The following is a description of a gene set: The replication of a centrosome, a structure comprised of a pair of centrioles and peri-centriolar material from which a microtubule spindle apparatus is organized. Mouse Gene Set: GOBP_CENTROSOME_DUPLICATION species: Mus musculus, and this is the list of marker genes: Ccdc57 (coiled-coil domain containing 57), Plk2, Chmp4c (NCBI Gene Id 74324), Cep152, Nat10, Vps4b, Brsk1, D7Ertd443e, Chmp3, Rock2, Cenpj, Pdcd6ip, Stil, Cdk5rap2, Fbxw5 (F-box and WD-40 domain protein 5), Xrcc3 (NCBI Gene Id 74335), Cenatac, Ckap5, Ppp1r35, C2cd3, Ccp110, Wdr90, Nup62, Chmp2b, Cep295nl, Cetn2, Cep120, Nubp1, Pkhd1, Chmp4b, Ccdc15, Brca2, Cep131, Cep135, Chmp5, Cdk2, Xpo1, Mdm1, Cep76 (centrosomal protein 76), Trim37, Rttn, Rbm14, Itgb1bp2 (NCBI Gene Id 26549), Cep63, Cetn1, Kat2a (K(lysine) acetyltransferase 2A), Cetn4, Wdr62, Kat2b, Gen1, Ndc80, Usp33, Alms1, Chmp1a, Npm1, Cep295, Poc1a, Cep85, Brca1, Nde1 (nudE neurodevelopment protein 1), Ccnf, Arhgef10, Sirt1, Cep44, Cep72, Cntrob, Tmem67, Cep192, Sac3d1, Ofd1, Plk4, Sass6, Deup1 (deuterosome assembly protein 1), Poc1b, Chmp2a, Spice1, Azin1, Chordc1, 4933427D14Rik (NCBI Gene Id 97740), Kifc1, Poc5, Chmp1b